Given this list of marker genes FAAH2, DBI, DECR1, HAO2, ACADL, ACACA, RXRA, CYP2C9, PTGES2, HACD1, ACAA1, SCP2, PTGIS, ACOT13, ECI1, CYP1B1, ACOXL, MORC2, SLC27A1, ACOT11, HACL1, EPHX2, HSD17B8, HACD2, THEM5, GGT5, ACADVL, ACBD5, CBR4, SLC27A2, AWAT1, MMUT, PTGS1, ACOX3, THEM4, AKR1C3, PCCB, PHYH, PCCA, ALOX15B, ELOVL7 (ELOVL fatty acid elongase 7), SCD5, PTGES3, SLC25A17, HSD17B4, PPARD, ACOT9, ABCD1, ELOVL4 (ELOVL fatty acid elongase 4), PTGDS, PRKAG2 (NCBI Gene Id 7981), NUDT7, CBR1, DPEP1, CYP4F8, ELOVL2 (NCBI Gene Id 54898), MECR, ACOT7L, ELOVL3, ACSL4, GPX1, SLC25A20, NUDT19, GPX2, ACBD7, FADS2 (fatty acid desaturase 2), GGT1, ACSL1, ACLY, CYP4F3, CPT2 (carnitine palmitoyltransferase 2), ACAD10, ABCC1, GPX4, ALOX15, HPGDS, PLA2G4A, PTGR2, MID1IP1, DECR2, FASN, MLYCD, ELOVL6 (NCBI Gene Id 79071), TECRL, ECI2, PON2, THRSP, AMACR, NDUFAB1, ACSL5, ACSM3, PTGS2, MMAA, CYP4F11, CYP2C19, CYP2C8, ALOX5, PRKAA2, CROT, EHHADH, HADHB, HTD2, MAPKAPK2, HPGD, ACADM, ACACB, ACOT8, ACOT1, LTC4S, OLAH, ACAD11, FADS1, ALOXE3, PPT1, HADHA, CYP8B1, ACSBG2, ACOX1, ACBD4, ACSM6, ALDH3A2, MCEE, SLC27A3, ACAA2, HACD4, CYP4F2, PCTP, HADH, CPT1A, ALOX12B, CYP1A2, PRKAB2, LTA4H, ACBD6, ACOT2, ACSF3, ACSBG1, ACOT7, HSD17B3, FAAH, HACD3, CYP1A1, SCD, ACOT4, CPT1B, ACSL3, ECHS1, TECR, CRAT, PPT2, ACSF2, CYP4A22, ACOX2, ACOT12, CYP2U1, PON1, PON3, CYP2J2, PTGES, PTGR1, PRXL2B, ALOX5AP, ACSL6, ELOVL1, HSD17B12, PECR, CYP4A11, SLC22A5, ACADS, MCAT, ALOX12, DPEP2, CYP4F22, CYP4B1, TBXAS1, ELOVL5, here is a description of the gene set: studied in species Homo sapiens The synthesis and breakdown of fatty acids are a central part of human energy metabolism, and the eicosanoid class of fatty acid derivatives regulate diverse processes in the body (Vance & Vance 2008 - URL). Processes annotated in this module include the synthesis of fatty acids from acetyl-CoA, mitochondrial and peroxisomal breakdown of fatty acids, and the metabolism of eicosanoids and related molecules. Reactome Pathway: Fatty acid metabolism part of: Metabolism of lipids